The following is a description of a gene set: from publication Kasturi SP, Skountzou I, Albrecht RA, Koutsonanos D, Hua T, Nakaya HI, Ravindran R, Stewart S, Alam M, Kwissa M, Villinger F, Murthy N, Steel J, Jacob J, Hogan RJ, García-Sastre A, Compans R, Pulendran B (PMID 21350488) Genes down-regulated in B lymphocytes immunized with: imiquimod versus monophosphoryl lipid A and imiquimod. species: Homo sapiens Many successful vaccines induce persistent antibody responses that can last a lifetime. The mechanisms by which they do so remain unclear, but emerging evidence suggests that activate dendritic cells (DCs) via Toll-like receptors (TLRs). For example, the yellow fever vaccine YF-17D, one of the most successful empiric vaccines ever developed, activates DCs via multiple TLRs to stimulate pro-inflammatory cytokines. Triggering specific combinations of TLRs in DCs can induce synergistic production of cytokines, which results in enhanced T cell responses, but its impact on antibody responses remain unknown. Learning the critical parameters of innate immunity that programs such antibody responses remains a major challenge in vaccinology. We demonstrated that immunization of mice with synthetic nanoparticles containing antigens plus Toll-like receptor (TLR) ligands 4 (MPL) + 7 (R837) induces synergistic increases in antigen-specific, neutralizing antibodies compared to immunization with a single TLR ligand. To determine whether there was any early programming of B cells, we isolated isotype switched, TCRbeta-CD11b-CD19+IgD-IgG+ B cells by FACS at 7 days post immunization with nanoparticles containing various adjuvants plus OVA, and performed microarray analyses to assess their molecular signatures. Human Gene Set: GSE25677_R848_VS_MPL_AND_R848_STIM_BCELL_DN, and this is the list of marker genes: MIR188, SLC39A10, EIF3K, ATPSCKMT, COG2, ST3GAL1, CIMAP1C, CYFIP2, RAB36, FAM3D, CDCA7, BTK, CSDE1, PIK3IP1, SIRT1, CIRBP, KLK5, SKA2, CEP55, TRA2B, HIBCH, PICALM, SLA, GKAP1, ACP5, LSP1 (lymphocyte specific protein 1), USP3, GNPDA2, IMMT, MTMR1, TRIP4, EXOC1, GGCT, SESN1, GET3, NCOA2, TJAP1, CCNI, POLR1B, IRF8, HCFC2, E2F7, SRGN, STARD7, PXMP4, INCENP, FOXO1, DHX9, EIF4A3, DNAJA2, INPP4B, RAP1B, NHEJ1, ADRB2, DESI2, IRS4, TAGLN, PPP1R21, GATAD2A, ZFAND5, BCAP29, GOLIM4, RIN3, ALG5, CSRNP1, ST6GALNAC1, UQCRQ, GPD1, RAB30, JAK2, WDR83, SSH2, CMAHP, SNX4, NIBAN3, IDI1, CAPZA1, OTULIN, ZNF318, GMFG, PGRMC2, HHAT, BRCC3, GAREM1, HSCB, TOP2A, CRLF3, FEZ2, ANKRD53, ARHGEF18, WWP2, HS3ST1, YBX1, PSMD7, MRPL57, MAPK6, AK2, PMPCB, PRKCE, EXD2, SF1, APOBEC1, ARAP2, ANXA1, DPY19L3, HERC4, SGK3, CASP7, ATP6V1C2, BTG1, MAP3K1, USP22, PCNA, MARCHF1, RAPGEF1, PAN3, THAP11, RIPOR2, AKAP13, MTCP1, RPS9, SNX32, DBF4, CECR2, CD72, TBR1, WAS, WDR46, EPHX1, SH3KBP1, WBP1, APOE, SKA2P1, GLRX3, USP15, SPRED2, PIM1, ATP6V1H, APIP (NCBI Gene Id 51074), MAP3K5, EEF1G, AKAP8L, SMURF2, GABBR1, KLHL6, SS18, MTA2, SATB1, OTUD4, SMC5 (structural maintenance of chromosomes 5), RAP1GDS1, MYPN, MKNK2, SPCS3, OXCT1, ATMIN, CXCR4, GALNT1, KIF20B, CEP57, KLHL28, PTPN22, PDCD4, TSC22D3, PKIG, GPRC5B